The following is a description of a gene set: Human Gene Set: GOBP_REGULATION_OF_TETRAPYRROLE_METABOLIC_PROCESS studied in species Homo sapiens Any process that modulates the frequency, rate or extent of tetrapyrrole metabolic process., and this is the list of marker genes: ABCB10, TMEM14C, CLYBL, TMEM14B, ABCB7, TMEM14EP, SLC6A9, SRRD, TMEM14A, TMEM14DP